Given this list of marker genes TMEM42, TMEM70, ATP10A, MOCS2, NFKBIE, IRF1, FARSA, LAP3, COMMD4, PTGR2, TAMALIN, NISCH, NINJ1, KIDINS220, IMP4, PDE2A, ITCH, SPATA24, SLC37A4, RAB14, FUCA2, PRR3, PSMA3, NLRC5, ARHGEF1, IPO5, FGL2, MED10, PKD2, FLT3 (fms related receptor tyrosine kinase 3), PLSCR1, CDIP1, LYN, ZNHIT3, DRG1, SAR1A, ITPRIPL2, GEMIN6 (NCBI Gene Id 79833), UTP20, NDUFA3, PRKCD, IMMP2L, TET1, SLC9A9, UTP11, ZNF764, APPBP2, XPO6, EPSTI1, ITGB2, C12orf57, RPL13A, PARP8, SELENOP, NCBP2AS2, CD79B, TMEM168, INSIG1, ANKRD44, GTF3C4, ZNF799, SDHD, AFF3, SLCO3A1, CA1, TELO2, LDAH, SGCB, JMJD1C, MGAT4A, RPS6KA3, MRPL50, TOMM40, TOR3A, TMEM178A, IFT27, CBX2, RHOH, SIAE (NCBI Gene Id 95985), MBD1, RAI1, CORO1C, ETFDH, LRRC1, ZXDC, UBE2J2, SAE1, POLR3G, HTRA2, URGCP, TNFRSF18, TIMM8B, PLPP6, NCK1, RTCA, TBL1X, KRT18, SMG1, B3GALT6, MTHFD1L, CBFA2T2 (CBFA2/RUNX1 partner transcriptional co-repressor 2), PEX5, DMTF1 (cyclin D binding myb like transcription factor 1), ARHGAP45, TRAM2, ATP13A2, NIPSNAP1, TYK2 (NCBI Gene Id 7297), GYG1, TARS2, TRAPPC8, BTBD1, WDR77, PNPLA7, TRIM47, STAT4, PPHLN1, COQ4, HEATR6, ARFGEF1, NOP56, SLC25A1, IDS, ORC4, SLC25A26, RNF217, CEPT1, MLLT6, LAMTOR4, SPI1, EFR3A, LONP1, GALNT2, PRMT1, DIAPH2, GPR180, DNLZ, ITGB7, SNRPF, NDUFB2, ATP6V1F, SYK, OGFOD1, AIFM1, GABPA, SUFU, PIP4P2, YTHDF1, AMZ2, SIGMAR1 (sigma non-opioid intracellular receptor 1), TOGARAM1, SFXN2, CAD, MCEE, UQCR11, NDUFS3, ZDHHC4, CDK9, ZNF560, BET1, KDM1A (lysine demethylase 1A), TSKS, TIFAB, RHOBTB3, MRPL45, TMEM192, PIGK, SLC30A6, PSMA4, SEC63, KHDRBS1, RBM27, PSMB4, YIPF5 (Yip1 domain family member 5), CHD9 (NCBI Gene Id 80205), MCMBP (NCBI Gene Id 79892), CCDC86, TPD52L2, POP1, PPM1H, CASP7, RER1 (NCBI Gene Id 11079), GTF2F2, KIF1C, QNG1, CNBP, FBXL4, MEX3B, RACK1, ZNF7, GM2A, TMEM181, MPEG1, ARL5A, ZNF569, NUP155, C6orf136, PARD3B, MRPL2, PPP2CB, here is a description of the gene set: Each fraction of mouse hematopoietic cells was purified by cell sorting from bone marrow of 8-week-old C57BL/6 mice, and its gene expression was analyzed. species: Homo sapiens Genes up-regulated in comparison of lineage negative versus erythroblasts. Human Gene Set: GSE27786_LIN_NEG_VS_ERYTHROBLAST_UP from publication Konuma T, Nakamura S, Miyagi S, Negishi M, Chiba T, Oguro H, Yuan J, Mochizuki-Kashio M, Ichikawa H, Miyoshi H, Vidal M, Iwama A (PMID 21540074)